Given this list of marker genes Gngt2, Gng4, Gng11, Gng10, Gna14, Gnb2, Gna13, Gng3, Tbxa2r, Gnb5, Gng8, Gng5, Gnb3, Gng7, Gngt1, here is a description of the gene set: This event has been computationally inferred from an event that has been demonstrated in another species.<p>The inference is based on the homology mapping from PANTHER. Briefly, reactions for which all involved PhysicalEntities (in input, output and catalyst) have a mapped orthologue/paralogue (for complexes at least 75% of components must have a mapping) are inferred to the other species. Reactome Pathway: Thromboxane signalling through TP receptor electronically inferred by orthology from the curated human pathway studied in species Mus musculus part of: Signal amplification